The following is a description of a gene set: Genes up-regulated in U2OS cells (osteosarcoma) upon knockdown of HDAC1 by RNAi. studied in species Homo sapiens Posttranslational modifications of core histones are central to the regulation of gene expression. Histone deacetylases (HDACs) repress transcription by deacetylating histones, and class I HDACs have a crucial role in mouse, Xenopus laevis, zebra fish, and Caenorhabditis elegans development. The role of individual class I HDACs in tumor cell proliferation was investigated using RNA interference-mediated protein knockdown. We show here that in the absence of HDAC1 cells can arrest either at the G(1) phase of the cell cycle or at the G(2)/M transition, resulting in the loss of mitotic cells, cell growth inhibition, and an increase in the percentage of apoptotic cells. On the contrary, HDAC2 knockdown showed no effect on cell proliferation unless we concurrently knocked down HDAC1. Using gene expression profiling analysis, we found that inactivation of HDAC1 affected the transcription of specific target genes involved in proliferation and apoptosis. Furthermore, HDAC2 downregulation did not cause significant changes compared to control cells, while inactivation of HDAC1, HDAC1 plus HDAC2, or HDAC3 resulted in more distinct clusters. Loss of these HDACs might impair cell cycle progression by affecting not only the transcription of specific target genes but also other biological processes. Our data support the idea that a drug targeting specific HDACs could be highly beneficial in the treatment of cancer. from publication Senese S, Zaragoza K, Minardi S, Muradore I, Ronzoni S, Passafaro A, Bernard L, Draetta GF, Alcalay M, Seiser C, Chiocca S (PMID 17470557) Human Gene Set: SENESE_HDAC1_TARGETS_UP, and this is the list of marker genes: CXCL3, CD44, CLDN12, GSR, MYH16, NAP1L1, GTF2I, BCL2L1, ALPL, SF3B1, USP32, ATP13A3, CYP1A1, TFE3 (transcription factor binding to IGHM enhancer 3), ZC3H12A, SPOPL, C3, MYC, POMGNT1, ANTXR2, EPRS1, KIAA1217, ATP6V0A4, AKR1C1, SERINC3, GLYR1, RNASE7, CEP170, ZBTB38, NRIP3, YWHAZ, PRDM2, UEVLD, NETO1, UTP23, LYPLA1, SPRED1, IFI16, DUSP3, IQGAP1, MYO6, RDUR, TGM2, NFYA, IL7R (interleukin 7 receptor), AP1S3, MTMR2, SRGN, MTAP, TMEM156, CDKL1, ZNF644, TCN1, TRIB1, MYCT1, GLIPR1 (NCBI Gene Id 11010), PNRC2, MLKL, TMEM259, SNHG16, MGST1, ODAPH, MAX, KLF3, TEX261, AKIRIN2, MBNL1, DUS3L, EIF4G1, ESYT2, TOP1, HACD2, ESM1, IL6ST, RPAP3, KIRREL1, PNP, SINHCAF, PI3, GLRX, ZNF317, KMT5AP1, TFPI, VKORC1L1, ATP11B, KYNU, PLAU, IDS, CEBPD, CTDSPL2, TEAD1, RASSF8, PDE12, PLEC, MMP9, PARD6B, COPA, MAP4K5, TMEM64, CARNMT1, WDR6, RPL27A, NFKBIZ (NFKB inhibitor zeta), TGFBR2, SRPRA, UHMK1, YRDC, TNFRSF11B, SLAIN2, DUSP5, NAV3, GM2A, SLC6A15, ARHGDIA, UPP1, ADAM10, NAMPT, CXCL5, BACH1, DEGS1, FBXW11, STEAP3, EPG5, PLEKHB2, PNO1, IGF2BP2, DNAJB14, CANT1, STIP1, TPP1, SLC16A1, EXOC5, BCL2A1, RGMB, REEP3, IL13RA2, AADAC, DOCK4, BDP1, DESI1, KDM1B, LMAN1, HSF1, LAMC2, ZC3HAV1L, DNAJB9, SOD2, TOR1AIP1, APH1A (NCBI Gene Id 82089), DSG2, ERRFI1, GNA13, B4GALT6, KBTBD8, RNF6, GCH1, DDAH1, PTBP3, ASPH (aspartate beta-hydroxylase), TMEM158, DDX42, CHST11, LINC00520, GEM, SKP2, OTUD4, LRRC58, LIG4 (DNA ligase 4), OGFRL1 (opioid growth factor receptor like 1), SLC43A3, SRPX, TMEM154, KITLG, TMEM41A, KPNA4, TASOR2, LAMB3, MEX3C, ARHGAP5 (NCBI Gene Id 394), SPAG1, FOSL1, DUSP7, AKT1S1, MAP3K2, YOD1, POLDIP3, CREM, LGALS8, SLC25A37, CYB5R2, STX16, NUP58, ETS1 (ETS proto-oncogene 1, transcription factor), CEP20, CBFB, SLC7A6, CPEB4, NBPF14, CSF2, RESF1, ZBED2, LTB, SNAP23, TRIM8, NLRP3, CELF1, PLK4, PTPRR, TMOD3, PAPOLA (poly(A) polymerase alpha), LARS1 (NCBI Gene Id 56885), CTNNA1, NAB1, MPP4, TMPO, ANAPC5, ABCC4, TRIO, SMG7, MMP1, PDE4DIP, PRR9, TMED2, USP34, FCHO2, FAS, ZFR, AGO2 (NCBI Gene Id 286109), TRUB1, ITPRIP, MTMR1, RAB8B, HECTD1, SERPINB8, CHRNA9, PTX3, OGDH, ITGA2, DLG1, TFRC, GALC, HSP90AB1, ACTR2, NXT2, ENTPD4, PHTF2, PCGF5, DESI2, LSM12, SPANXA1, BIRC3, GULP1, CCL20, OLAH, SERPINB2, SLCO4A1, MSANTD4, TPR, TRIM38, SUPT6H, CCNE2, SLC7A1, SLAMF7, SCYL2, USP16, IL1A, STRN, HMGA1, CDK6, ITPR1, OTUB2, GART, FOXD1, RGS4, IL1RAPL1, CDV3, SLC39A14, ST6GALNAC4, ROBO4, TAF9B, NSMAF, SNX19, MCM4, SGPP1, NEAT1, LETM2, PAX8-AS1, BUB1, PSME4, NPAS2, USP12P1, LPXN, SLC7A11, DHX9, SETD5, HDAC9, MFAP3, COL22A1, WAKMAR2, ITPRID2, MIR3142HG, PTPN11, MET (MET proto-oncogene, receptor tyrosine kinase), YTHDF3 (NCBI Gene Id 253943), KBTBD2, GNG12, C6orf58, ITGA6, EXTL3, RRN3, ADAMTS6 (NCBI Gene Id 345667), STK26, LDB2, PDLIM4, FUS, CCND2, TAOK1, CXCL8, HYCC1 (NCBI Gene Id 84668), DGKI, AHCTF1, CERS6, TWF1, EIF5A2, SLC6A6, SLC39A8, NFKB2, LINC02806, SQSTM1, CAPRIN1, CCL2, NFS1, LY96, ZMAT3, PTBP1, TRIML2, DIMT1, CCL3, CD55, CXADR, SCG5, SEC61A1, C4orf46, PTPN12, DCP2, PLIN2, ABCC9, MMP3, PRSS35, ELK3, BCLAF1, CSGALNACT2, TNFAIP3, RAB6A, GPR65, SRRT, RB1, STX3, G0S2, DCLK1, ARL14, VEGFC, PSAT1, NUS1P3, LCP1, NEDD4L, IGF2BP3, CNOT1, SAA1, SPANXB1, RAB35, GPR3, CILK1, IL24, PIP5K1A, PHACTR2, PPFIBP1, AADACP1, SUPT16H (NCBI Gene Id 6831), MOB1A, AKT3, IL6R, DLGAP1-AS2, CHD4, FKBP15, SLC39A6, TNFRSF10B, FN1, GPCPD1, DDX3X, PLEKHM1, TMX1, TGFBR1, SPRED2, OSMR, LNCAROD, MAFF, CYTH3, EZR, BMP2, GSK3B, LINC00973, DOCK10, MCL1, G3BP2, JAM3, FGD6, GPAT3, ATP11A, PRNP, PXN, RAC2 (NCBI Gene Id 5880), JPT2, KLHL21, GRPEL2, NFE2L2, PPIF, MAST4, RBM14, IRAK2, KISS1, SZRD1, ESCO2, PIK3C2A, MAOA, USP10, CDC27, CDC42SE2, SKIC3, PRPF6, PRIM2, MEAK7, DCTN5, CA2, FBXO38, CPNE5, ZNF655, MOSPD1, PTHLH, TNFRSF12A, ASAH2, TM4SF1, VEGFA, NABP1, LINC02915, PPTC7, NFKBIA, SSR3, MLX, DPY19L1, TFAM, COBLL1